The following is a description of a gene set: Nuclear receptors species: Homo sapiens Human Gene Set: WP_NUCLEAR_RECEPTORS, and this is the list of marker genes: PPARD, NR1I3, RORA, NR2C2, NR5A1, PGR, NR3C1, THRA, NR1D2, NR1H3, PPARA, NR0B1, THRB, ROR1, NR1I2, HNF4A, RXRA, NR2F2, NR5A2, RXRG, ESR2, ESR1, RARB, NR2F6, RORC, NR1H2 (nuclear receptor subfamily 1 group H member 2), NR4A2, PPARG, RARA, VDR, AR, ESRRA, NR2F1 (NCBI Gene Id 7025), RXRB, RARG, NR2E1, ESRRB, NR4A1